The following is a description of a gene set: species: Homo sapiens from publication Coulouarn C, Factor VM, Thorgeirsson SS (PMID 18506891) Hepatocellular carcinoma (HCC) is one of the most common cancers in the world. The clinical heterogeneity of HCC, and the lack of good diagnostic markers and treatment strategies, has rendered the disease a major challenge. Patients with HCC have a highly variable clinical course, indicating that HCC comprises several biologically distinctive subgroups reflecting a molecular heterogeneity of the tumors. Transforming growth factor beta (TGF-beta) is known to exhibit tumor stage dependent suppressive (that is, growth inhibition) and oncogenic (that is, invasiveness) properties. Here, we asked if a TGF-beta specific gene expression signature could refine the classification and prognostic predictions for HCC patients. Applying a comparative functional genomics approach we demonstrated that a temporal TGF-beta gene expression signature established in mouse primary hepatocytes successfully discriminated distinct subgroups of HCC. The TGF-beta positive cluster included two novel homogeneous groups of HCC associated with early and late TGF-beta signatures. Kaplan-Meier plots and log-rank statistics indicated that the patients with a late TGF-beta signature showed significantly (P < 0.005) shortened mean survival time (16.2 +/- 5.3 months) compared to the patients with an early (60.7 +/- 16.1 months) TGF-beta signature. Also, tumors expressing late TGF-beta-responsive genes displayed invasive phenotype and increased tumor recurrence. We also showed that the late TGF-beta signature accurately predicted liver metastasis and discriminated HCC cell lines by degree of invasiveness. Finally, we established that the TGF-beta gene expression signature possessed a predictive value for tumors other than HCC. CONCLUSION: These data demonstrate the clinical significance of the genes embedded in TGF-beta expression signature for the molecular classification of HCC. 'Early-TGFB1 signature': genes overexpressed in primary hepatocytes at an early phase of TGFB1 treatment; is associated with a less invasive phenotype. Human Gene Set: COULOUARN_TEMPORAL_TGFB1_SIGNATURE_DN, and this is the list of marker genes: SLC2A8, REX1BD, CYP51A1, CCDC85A, TMEM127, ERRFI1, GADD45A, SELENOP, TP53INP1, GSDMD, PPFIBP2, CYP3A7, PCDH1, HAMP, NSMCE3, RASSF5, COL18A1, PCYT2, SLC25A37 (NCBI Gene Id 55881), SNAI1, TTC39C, NHERF1, UGT2B10, OSGIN1, HCN2, PRG4, IRF2BPL, DHCR24, GADD45G, GLUL, ABCC3, CXCL12, TRIB3, SCP2, NFKBIA, IGFBP3, ACVR1B, GADD45B, DUS1L, DHRS1, ARID3A, ARID5B, FDPS, ACSL3 (acyl-CoA synthetase long chain family member 3), STX5, SLC35C1, SVIL, GSTA1, RAPGEF2, DEPDC7, TGM1, SERINC2 (serine incorporator 2), TM7SF2, GSTO1, BAG3, RHOB, SORBS2, FGF8, SERPIND1, ALAS1, HIPK2, RELB, ENTPD5, CHP1, ARHGAP6, HCRT, HMGA2, NDEL1, ALCAM, MSMO1, TSC22D2, CHKA, ALDH1A1, STOM, LDLR, H2BC15, C1orf115, SLC26A1, UGT2B15, DDX28, LGALS3, CLUH, DUSP3, CDA, MSRB1, DGAT2, CTNND1, GSE1, METTL26, RSC1A1 (regulator of solute carriers 1), DYRK3, SULT1E1, SLC23A2, ID2B, IDH1, FARSB, LRP1, ALDH3A2, MAPRE3 (microtubule associated protein RP/EB family member 3), CPN1, ZSWIM4, CXADR, GRHPR, RAB17, ALDOB, GPD1, CBS, ZFP36L2, IGFBP4, LPIN2, EPS8L2, SELENBP1, SPRR1A, HABP2, SPPL3, SREBF2, ABCB1, ACVR1, SLC25A13, HMGCS1, TNK2, GK, BMPR2 (NCBI Gene Id 659), GJB2 (gap junction protein beta 2), GCNT2, SH3BP2, CA8, DHCR7, HPGD, TSPYL2, PLPP3, CXXC5, JAG1, GPT, UBE2L6, GSS, DUSP6, MOSPD3